Given this list of marker genes St3gal3, St6galnac5, Ugt8a, St8sia5, Fut1, St3gal5, B4galt6, Ugcg, Fut2 (fucosyltransferase 2), St3gal2, B3gnt5, B3galnt1, Cerk, B3galt4, Gal3st1, A4galt, B4galt5, St6galnac6, B4galnt1, here is a description of the gene set: Glycosphingolipid biosynthesis species: Mus musculus Mouse Gene Set: REACTOME_GLYCOSPHINGOLIPID_BIOSYNTHESIS